The following is a description of a gene set: studied in species Homo sapiens Any process that stops, prevents, or reduces the frequency, rate or extent of the directed movement of lipids into, out of or within a cell, or between cells, by means of some agent such as a transporter or pore. Human Gene Set: GOBP_NEGATIVE_REGULATION_OF_LIPID_TRANSPORT, and this is the list of marker genes: APOE (NCBI Gene Id 99), SREBF2, MIR93, PLA2R1, SHH, APOC3, MIR19B1, ABCA2, CRY2, MIR613 (microRNA 613), PCSK9, MIR130B, ITGB3, MIR206, NR1H3, MIR301B, MIR33A, ADIPOQ, KCNK9, AKT1, NR1H2, PLA2G10, MIR758, MIR128-1, APOA2, MIR17, ACSL4, MIR27B, MIR27A, MIR145, MIR9-1, ITGAV, MIR148A, APOC2, MIR302A, TSPO, MIR144, NFKBIA, MIR30C1, CYP4F2, IRS2, FIS1, EGF, AKT2, MIR33B, MAPK3, CRY1, APOC1, MIR185, PTPN11, MIR26A1, THBS1